Given this list of marker genes Dhx9, Arb2a, Prkra, Tarbp2, Mecp2, Tlr9, Dicer1, Ago2, Tlr7, Fmr1, Mbd2, here is a description of the gene set: species: Mus musculus Binding to a small interfering RNA, a 21-23 nucleotide RNA that is processed from double stranded RNA (dsRNA) by an RNAse enzyme. Mouse Gene Set: GOMF_SIRNA_BINDING